Given this list of marker genes Ascl2, Ski, Gba1, Cdkn2b, Mfn2 (NCBI Gene Id 170731), Vegfc, Orc3, Ptn, Sox4, Abcc8, Atxn1, Nf2, Rb1, Notch1, Sox11, Fas, E2f1, Mtor, Egfr, Cers2, Ptk2b, Tnf, Arrb2, Nrg1, Cysltr1, Ctnnb1, Prkci, Penk, Areg, Dbi, Sox10, Slc7a5, Myb, Anxa7, Mecp2, Ndp, Nf1, Creb1, Ifng, Tspo, Prkch (protein kinase C, eta), Epm2a, Shh, Hes1, Dicer1, Csf1, Ppp1cc, Idh2, Lyn, Plag1, Pmp22, Tert, Ptk2, Vim, Gfap, Il34, Il33, Il1b, Nfib, Myc, Csf1r, Adcyap1, Il6, Igf1, Cx3cl1, Kras, Ntn1 (NCBI Gene Id 276903), Lgi4, Nfix, Clu, Trem2, Shank3, Lepr, Flt1, Lta, Nfia, Etv5 (NCBI Gene Id 75752), Ufl1, Cntnap2, Cysltr2, Trp53, Rnf10, here is a description of the gene set: Mouse Gene Set: GOBP_GLIAL_CELL_PROLIFERATION The multiplication or reproduction of glial cells by cell division, resulting in the expansion of their population. Glial cells exist throughout the nervous system, and include Schwann cells, astrocytes, and oligodendrocytes among others. studied in species Mus musculus